Given this list of marker genes SLC6A19, here is a description of the gene set: part of: SLC transporter disorders SLC6A19 encodes the sodium-dependent neutral amino acid transporter B(0)AT1 and mediates the uptake of neutral amino acids across the plasma membrane accompanied by uptake of a sodium ion. The protein is abundantly expressed in the small intestine and kidney (Broer & Gether 2012, Schweikhard & Ziegler 2012). Defects in SLC6A19 can cause Hartnup disorder (HND; MIM:234500), an autosomal recessive abnormality of renal and gastrointestinal neutral amino acid transport characterised by increased urinary and intestinal excretion of neutral amino acids. Symptoms include transient manifestations of rashes, cerebellar ataxia and psychotic behaviour. Some mutations in SLC6A19 are thought to contribute to the phenotypes iminoglycinuria (IG; MIM:242600) and hyperglycinuria (HG; MIM:138500). species: Homo sapiens Reactome Pathway: Defective transport of amino acids by SLC6A19 causes Hartnup disorder (HND)